Given this list of marker genes MTSS1, PTPRO, SALL1, GATA3, FOXJ1 (NCBI Gene Id 2302), STAT1, LIF, PRKX, PAX2, EXT1, PROM1, LHX1, YAP1, BASP1, OSR1, WNT4, GLI3, SMO, TCF21, FOXC2, CD2AP (CD2 associated protein), SHH, CD24, SIX2, JAG1, MMP9, AMPD2, CD34, AMER1, LAMB2, WWTR1, GDNF, WT1, CTNNB1, NOTCH2, NPHS1, MEF2C, GLIS2, PDGFB (platelet derived growth factor subunit B), KLF15 (KLF transcription factor 15), PODXL, WNT9B, NPHS2, EDN1, POU3F3, EDNRB, HES1, GPR4, GREM1, MYO1E, PTCH1, IQGAP1, ADIPOQ, ASXL1, EDNRA, MAGI2, ACTA2, PAX8, NOTCH1, here is a description of the gene set: Human Gene Set: GOBP_CELL_DIFFERENTIATION_INVOLVED_IN_KIDNEY_DEVELOPMENT The process in which relatively unspecialized cells acquire specialized structural and/or functional features that characterize the cells of the kidney as it progresses from its formation to the mature state. species: Homo sapiens